Given this list of marker genes Rps3a1, Rps21, Rps28, Phactr3 (NCBI Gene Id 74189), Rpl31, Rpl36, Bcl2a1b, Rpl36a, Eef1g, Rps20, Cd160, Rps7, Il7r, Eef1a1, Rpl39, Rps10, Rps16, Rpl13 (ribosomal protein L13), Rps15a-ps6, Rps12, Rps17, Rpl22, Rpl11, Rps13, Rps25, Rps15a-ps4, Rpl35a, Rps29 (ribosomal protein S29), Lag3, Rpl12, Rpl27, Mfsd10, Rpl38, Gimap7, Bcl2a1d, Rpl35, Ly6e, Rplp1, Rpl5, Rps18, Cd3d, Asb2, Psmb8, Nrgn, Rpl13a, Uba52, Lpxn, Rpl17, Rps3, Tmsb10, Rplp2, Itm2c (NCBI Gene Id 98594), Rps27a, Rps24, Rpl6, Rgs1, Xcl1, Rps26, Cd7, Rpl37, Rpl41, Tox (NCBI Gene Id 76569), Klk8, Mbnl1, Cirbp, Tpt1, B2m, Jchain, Kit, Romo1 (reactive oxygen species modulator 1), Rpl28, Rpl21, Serpina3g, S100a9, Gm4956, Rps15a, Ltb, Thy1, Rpl23, Rpl14, Rps8, Rps11, Rpl37a, Rab8b, Cxcr3, Spint2, Rpl23a, Dleu2, Gm9320, Cd3g, Rbm3, H2-K1 (histocompatibility 2, K1, K region), here is a description of the gene set: species: Mus musculus from publication Tabula Muris Consortium (PMID 32669714) Mouse Gene Set: TABULA_MURIS_SENIS_SPLEEN_NK_CELL_AGEING